The following is a description of a gene set: studied in species Mus musculus Human Gene Set: CADWELL_ATG16L1_TARGETS_DN Susceptibility to Crohn's disease, a complex inflammatory disease involving the small intestine, is controlled by over 30 loci. One Crohn's disease risk allele is in ATG16L1, a gene homologous to the essential yeast autophagy gene ATG16 (ref. 2). It is not known how ATG16L1 or autophagy contributes to intestinal biology or Crohn's disease pathogenesis. To address these questions, we generated and characterized mice that are hypomorphic for ATG16L1 protein expression, and validated conclusions on the basis of studies in these mice by analysing intestinal tissues that we collected from Crohn's disease patients carrying the Crohn's disease risk allele of ATG16L1. Here we show that ATG16L1 is a bona fide autophagy protein. Within the ileal epithelium, both ATG16L1 and a second essential autophagy protein ATG5 are selectively important for the biology of the Paneth cell, a specialized epithelial cell that functions in part by secretion of granule contents containing antimicrobial peptides and other proteins that alter the intestinal environment. ATG16L1- and ATG5-deficient Paneth cells exhibited notable abnormalities in the granule exocytosis pathway. In addition, transcriptional analysis revealed an unexpected gain of function specific to ATG16L1-deficient Paneth cells including increased expression of genes involved in peroxisome proliferator-activated receptor (PPAR) signalling and lipid metabolism, of acute phase reactants and of two adipocytokines, leptin and adiponectin, known to directly influence intestinal injury responses. Importantly, Crohn's disease patients homozygous for the ATG16L1 Crohn's disease risk allele displayed Paneth cell granule abnormalities similar to those observed in autophagy-protein-deficient mice and expressed increased levels of leptin protein. Thus, ATG16L1, and probably the process of autophagy, have a role within the intestinal epithelium of mice and Crohn's disease patients by selective effects on the cell biology and specialized regulatory properties of Paneth cells. from publication Cadwell K, Liu JY, Brown SL, Miyoshi H, Loh J, Lennerz JK, Kishi C, Kc W, Carrero JA, Hunt S, Stone CD, Brunt EM, Xavier RJ, Sleckman BP, Li E, Mizushima N, Stappenbeck TS, Virgin HW 4th (PMID 18849966) Genes down-regulated in Paneth cell (part of intestiinal epithelium) of mice with hypomorphic (reduced function) form of ATG16L1., and this is the list of marker genes: ZNF266, D2HGDH, USP53, SATB2, POT1, THOC1, CCDC88C, TTR, RAMAC, MCC, HAL, C5orf34, RCCD1, PER1, RALGPS2, TCHH, STOX2, IGHG1, SLC22A15, SULT1C2, VPS39, TUBGCP4, JMJD7, SNHG14, RNF187, NETO2, IVD, HAUS2, H3-3B, SMIM10L1, HSPA4L, HSPA1B, ARSK, PDK4 (NCBI Gene Id 5166, pyruvate dehydrogenase kinase 4), PPFIBP1, LRIG3, SFRP1, PPIP5K1, FUBP1, C15orf40, TMEM267, SGK1, GIP, DHRS1 (NCBI Gene Id 115817), PLET1, TMEM242, CLDN8, MTREX, GDAP2, NIBAN3, NFE2L2, P4HA1, PPARGC1A, AFG2B, FKBP5, CCDC32, NUP62, ST6GALNAC1, SCART1, IGHM, SLC15A2, YTHDC2, CAMK2D, RGS5, DNAJA4, OIP5 (NCBI Gene Id 123752), VCAM1, HSPA1A, CAP1